Given this list of marker genes JUN, SST, ALKBH3, PTPRK, ARHGEF1 (Rho guanine nucleotide exchange factor 1), SKIL, GJB3, HOXC5, GNGT1, TSC22D1, CLK1, IGDCC3, MAPKBP1, PLEK, NSFL1C, TRAPPC6A, EDN3, SLC25A25, SAA4, CCR7, YES1, ERRFI1, PAF1, SCG2, STAT5B, MYH9, NIPAL2, VIT, TMEM39A, MSI2, COQ4, IGSF6, KRTAP8-1, TUBGCP2, ICAM1, INHBA, TNFRSF11B, WSB1, IL4I1, SPTLC2, DUSP14, ERCC3, CXCL2, DUSP16, SYP (synaptophysin), CNTN6, ARHGEF3, MYO1C, ADAM33, KIF21B, RNF19A, PRDX6, GTF2B, CASP4, FZR1, ITGB6, GTF2IRD2, SUCO, OGFRL1, IRF8, NMRK1, VTI1A (vesicle transport through interaction with t-SNAREs 1A), IKZF2, PRRX2, SPINK4, MUC20, PTPN23, SLC6A8, SERPINB2, MED21, FPR1, ABHD17C (NCBI Gene Id 58489), DDX18, RAB20, SLC41A1, PAH, AQP7, OLR1, KMT2A, KRT16, ST3GAL5, FHOD3, PCSK1, SLC30A6 (NCBI Gene Id 55676), FERD3L, ANGPTL7, ACOD1, PSMB3, MTMR7, TRAT1 (NCBI Gene Id 51488), RTBDN, NSG2, ARL4A, MMP10, USP20, MMP14, TNIP1, FTSJ3, IL9R, PARP14, CD274, CDC42EP3, PTGER4, CFAP184, COL4A4, TYRP1, PTPRE, ZBTB17, KLKB1 (kallikrein B1), STK4, EGFL7, C6orf58, SLAMF7, SLC11A1, FST, GATA2, RD3, DPP4, IL6, TMA16, NOCT, LIN37, SAP18, BRD2 (NCBI Gene Id 9803), DTNB, TRIM62, TADA3, WNK2, TAF7, MET, MYBPH, HPCA, ADORA2B, PYY, PIM1, PATJ, DKK3 (dickkopf WNT signaling pathway inhibitor 3), FOXB2 (NCBI Gene Id 442425), SLC27A3, NFKBIA, CDHR1, SRMS, PIM3, PDE10A, OSGIN2 (oxidative stress induced growth inhibitor family member 2), IFNGR1, JUNB, CYBRD1 (cytochrome b reductase 1), TRHR, FSTL1, EMSY, EMILIN1, RARS2, KIF1B, LIN7B, ACOT7, ARHGAP45, GIPC3, DPEP3, EGR2, MAP2K2, TNFRSF9, SAMSN1, ITIH4, GEM, SEPTIN2, KRT77, SRY, STAB2, TLR7, SYTL4, ABHD8, TAC1, SPRR3, NCK1, SLC24A1, REST, SRXN1, POF1B, MMP13, COL4A5, NFKBIZ, CCK, KRTDAP, IL17D, ADM, ATF3, NLRX1, HORMAD1, PRKCSH, CCL13, MAFF, SPRY1, F3, DMRTB1, ZNF704, PHIP, BIRC3, MFSD6L, ZFP36, here is a description of the gene set: mouse primary BMDCs were stimulated with tlr ligands and gene expression changes were profiled on Affymetrix arrays studied in species Homo sapiens from publication Amit I, Garber M, Chevrier N, Leite AP, Donner Y, Eisenhaure T, Guttman M, Grenier JK, Li W, Zuk O, Schubert LA, Birditt B, Shay T, Goren A, Zhang X, Smith Z, Deering R, McDonald RC, Cabili M, Bernstein BE, Rinn JL, Meissner A, Root DE, Hacohen N, Regev A (PMID 19729616) Genes up-regulated in comparison of dendritic cells (DC) stimulated with Pam3Csk4 (TLR1/2 agonist) at 1 h versus DC cells stimulated with Gardiquimod (TLR7 agonist) at 1 h. Human Gene Set: GSE17721_PAM3CSK4_VS_GADIQUIMOD_1H_BMDC_UP